The following is a description of a gene set: Top 20 up-regulated genes in leukemic progenitor cells expressing activated fusion of ESWR1 and FLI1 compared to normal hematopoetic progenitors. EWS/FLI-1 is a chimeric oncogene generated by chromosomal translocation in Ewing tumors, a family of poorly differentiated pediatric tumors arising predominantly in bone but also in soft tissue. The fusion gene combines sequences encoding a strong transactivating domain from the EWS protein with the DNA binding domain of FLI-1, an ETS transcription factor. A related fusion, TLS/ERG, has been found in myeloid leukemia. To determine EWS/FLI-1 function in vivo, we engineered mice with Cre-inducible expression of EWS/FLI-1 from the ubiquitous Rosa26 locus. When crossed with Mx1-cre mice, Cre-mediated activation of EWS/FLI-1 resulted in the rapid development of myeloid/erythroid leukemia characterized by expansion of primitive mononuclear cells causing hepatomegaly, splenomegaly, severe anemia, and death. The disease could be transplanted serially into naïve recipients. Gene expression profiles of primary and transplanted animals were highly similar, suggesting that activation of EWS/FLI-1 was the primary event leading to disease in this model. The Cre-inducible EWS/FLI-1 mouse provides a novel model system to study the contribution of this oncogene to malignant disease in vivo. from publication Torchia EC, Boyd K, Rehg JE, Qu C, Baker SJ (PMID 17875932) species: Mus musculus Human Gene Set: TORCHIA_TARGETS_OF_EWSR1_FLI1_FUSION_TOP20_UP, and this is the list of marker genes: APOE, ALOX5, EPS8, PHLDA2, NUDT11, FMO1, MEST, CPNE7, NDRG2, GDA, ZNF185, SLAMF1, CDA, SERPINB2, HMGCS2, SLC6A20, NRIP3, CA8, CPNE5, FAM174B